The following is a description of a gene set: studied in species Mus musculus The directed movement of substances from the cytosol into the mitochondrion. Mouse Gene Set: GOBP_IMPORT_INTO_THE_MITOCHONDRION, and this is the list of marker genes: Slc25a36, Tomm40, Ucp2, Timm17b, Micu3, Tomm70a (NCBI Gene Id 70049), Micu1, Maip1, Vdac1, Timm44 (translocase of inner mitochondrial membrane 44), Tomm7, Psen2, Hspa9, Hif1a, Mcub, Sfxn3, Dnlz, Pam16, Grpel1, Fxn, Tomm40l, Tomm20l, Micu2, Slc25a32, Dnajc15, Timm17a, Timm50, Akt1, Timm21, Sfxn2, Romo1, Dnajc19, Slc25a33, Afg3l2, Slc25a28, Spg7, Slc25a23, Slc25a39, Mcur1, Slc25a37, Mcu, Tst, Timm23, Slc25a38, Sfxn1, Grpel2, Slc25a40, Tomm20, Mrpl18, Slc30a2, Itpr1, Pnpt1, Smdt1, Opa1